The following is a description of a gene set: The p53 gene is mutated in many human tumors. Cells of such tumors often contain abundant mutant p53 (mutp53) protein, which may contribute actively to tumor progression via a gain-of-function mechanism. We applied ChIP-on-chip analysis and identified the vitamin D receptor (VDR) response element as overrepresented in promoter sequences bound by mutp53. We report that mutp53 can interact functionally and physically with VDR. Mutp53 is recruited to VDR-regulated genes and modulates their expression, augmenting the transactivation of some genes and relieving the repression of others. Furthermore, mutp53 increases the nuclear accumulation of VDR. Importantly, mutp53 converts vitamin D into an antiapoptotic agent. Thus, p53 status can determine the biological impact of vitamin D on tumor cells. from publication Stambolsky P, Tabach Y, Fontemaggi G, Weisz L, Maor-Aloni R, Siegfried Z, Shiff I, Kogan I, Shay M, Kalo E, Blandino G, Simon I, Oren M, Rotter V (PMID 20227041) Genes induced in SKBR3 cells (breast cancer) by 25-hydroxyvitamin D3. Human Gene Set: STAMBOLSKY_RESPONSE_TO_VITAMIN_D3_UP species: Homo sapiens, and this is the list of marker genes: DNAH17, GNB1, STC1, PDE4B, CLCA2, EPHA4, ITGA2, DOCK1, SMOC1, TTC39C, SNTB2, ZBED1, CUL3, STMN3, CRADD, PAXBP1, VTN, TM9SF3, ADARB1, PRDM1, ZNF606, HACD2, GUSBP5, S100A7, ARHGEF28, TSPAN5, AREG, CYLC1, CLDN1, BGLAP (bone gamma-carboxyglutamate protein), RBMS1, ATP2B1, RPS27, ARHGEF7 (NCBI Gene Id 8874), SLC1A3, EVA1C, TM7SF2, BMPR1B, ERVW-1, SLC26A2, SOCS3, IL17C, CR1, DIO2, SLC44A5, CTBP2, MAP3K21, IFIT1, WDFY1, PDE3B, PLCL2, CYP24A1, CNGA3, FHL2, FMO9P, MCC, PDGFD, CADM1, DHX9, STK4, SLC4A7, CA9, ACACA, LIG4, LXN, TGIF1, DNAJC3, G6PD, IFNGR1, SH3TC1, WLS, TRIB2, SGPP2, CP, PNMT, IFNA7, SEC31A, P2RX2, KLK6, SLC45A4, STRN, OSCP1, CDK17, MALAT1